The following is a description of a gene set: Mouse Gene Set: GOMF_AMINE_TRANSMEMBRANE_TRANSPORTER_ACTIVITY studied in species Mus musculus Enables the transfer of amines, including polyamines, from one side of a membrane to the other. Amines are organic compounds that are weakly basic in character and contain an amino (-NH2) or substituted amino group., and this is the list of marker genes: Rhag, Slc44a1, Aqp8, Slc44a2, Flvcr1, Slc22a16, Slc6a14, Slc7a8, Slc18a2, Flvcr2, Slc22a2